Given this list of marker genes CCKAR, CCR5, CXCR5, OXTR, HTR7, GP1BB, NPY5R, ACKR2, EDNRB, CCR1, HCRTR1, NPY1R, CX3CR1 (C-X3-C motif chemokine receptor 1), C5AR1, CCL13, CCR2, GPR17, FPR1, CXCR4, OPRK1, CXCR6, C3AR1, EDNRA, MAS1, AVPR1A, BDKRB2, FPR2, NTSR1, GALR3, CCR4, here is a description of the gene set: Genes in the cancer module 134. Human Gene Set: MODULE_134 studied in species Homo sapiens